Given this list of marker genes ENG, CAV1, GDF2, SMAD4, ACVRL1, here is a description of the gene set: species: Homo sapiens Human Gene Set: HP_PULMONARY_ARTERIOVENOUS_MALFORMATION Pulmonary arteriovenous malformation Pulmonary arteriovenous malformation, a condition most commonly associated with hereditary hemorrhagic telangiectasia, is an abnormal communication between the pulmonary artery and pulmonary vein without an intervening capillary communication. HRCT images usually show a coarse spidery appearance of the peripheral vascular markings in the lungs. More specific findings are obtained in the pulmonary angiogram where the normally invisible capillary phase is replaced by irregular vascular channels bridging the peripheral branches of pulmonary arteries and veins.